The following is a description of a gene set: Deviation of toes studied in species Homo sapiens Human Gene Set: HP_DEVIATION_OF_TOES, and this is the list of marker genes: EIF4H (eukaryotic translation initiation factor 4H), SLC29A3, SRY, SCARF2, COG8, SLC16A2, LIMK1, GDF5, DNAJC30, ITCH, GNPNAT1, KCNJ5, HOXD13 (homeobox D13), FGFR2, ATL3, HEPHL1, TGFBR2, NONO, NFIX, NOG, PIGH, RFC2, IL11RA, ATP6V1B2, ALG3, C2CD3, B3GALT6, FKBP6, TBC1D2B, EIF4A3, ELN, GTF2IRD2, PYCR1, CREBBP, CLIP2, KCNJ2, CHSY1, TAF4, BMPR1B, FRA10AC1, NUP107, ACVR1, FGFR3, RAB3GAP2, HNRNPR, B3GAT3, AEBP1, ZEB2, H4C9, TTI2, TBL2, SALL1, STX1A, FGFR1, WWOX, KAT6A, BMP2, CKAP2L, EP300, ERF, MLXIPL, EHMT1, METTL27, ERMARD, GBA1, SMARCA2, CWC27, CHST11, FHL1 (four and a half LIM domains 1), VPS37D, DYRK1A, BAZ1B, DACT1, XYLT1, RBBP8, RSPRY1 (ring finger and SPRY domain containing 1), GTF2IRD1, CDKL5, SPTAN1, HOXA13, EZH2, KCNN3, FLI1, SCAF4, TP63, FLNA, FGF9, GTF2I, PCDHGC4, TWIST1 (twist family bHLH transcription factor 1), PSMB8, HEATR3, KCNH1, DLEC1, TRMT10A, ZNF668, SF3B4, BUD23 (NCBI Gene Id 84118), SOX9, ZMIZ1 (zinc finger MIZ-type containing 1), AKT1, RFX7, MYH3, TCF12, TMEM270, ZNF469, KDM5A, CHST3, YY1, USP9X, ZFX, PPP1R15B, ATP2B1, NCF1, SATB2 (NCBI Gene Id 80104), PRDM5, RNF6, USP7, COL1A2, COL1A1